Given this list of marker genes BLCAP, FMR1, TMEM25, TACR1, KLF7, KIAA1549L, ZNF292, MAP3K19, ADGRL2, NTNG1, SLC41A1, LASP1, TREM1, TBCA, NDC1, TMEM30B, ID3, IL18BP, ITGB1BP1, YTHDC1, CLDN9, DNAJA2, ODF2, ZBTB20, RAB38, PITPNM2, TRIM24 (NCBI Gene Id 8805), USP9X, SCNN1G, DPP6, PDXP, MTMR2, LRRC17 (leucine rich repeat containing 17), CHTF8, DENR, TADA3, CDC25B, SLC39A7, AP3S2, GSKIP, MAB21L3, ACVR1, USP46, SGCD, SMIM14, RGL1, NPNT, TOR1AIP2, DOP1A (DOP1 leucine zipper like protein A), EMC2, XPO7, CARNS1, FAM120C, TMEM234, SCN3B, CNTLN, COL13A1, MECP2 (methyl-CpG binding protein 2), PTMA, MYCBP2, TMEM132B, IGF2, COL18A1, ING1, SIRPB2, COQ10A, IDS, KDF1, ISY1-RAB43, RXRA, TEF, FJX1, MDGA2, GAS2, WIF1, DGKK, NCBP2, PTPRJ, MRPL49, ITPR3, GBP7, TMCC2, SLITRK4 (SLIT and NTRK like family member 4), SLC66A2, BNIP3L, FGF14, CDK16, CEP350, ONECUT2, LHFPL4, MTHFR (methylenetetrahydrofolate reductase), NCAPG, SLC6A6, ARPIN-AP3S2, HOGA1, TCF7L1, MICALL1, ZDHHC3, PHETA1, CYP27B1, here is a description of the gene set: Genes predicted to be targets of miRBase v22 microRNA hsa-miR-1972 in miRDB v6.0 with MirTarget v4 prediction scores > 80 (high confidence targets). Human Gene Set: MIR1972 from publication Chen Y, Wang X (PMID 31504780) species: Homo sapiens